The following is a description of a gene set: species: Mus musculus Mouse Gene Set: WP_OSTEOBLAST_SIGNALING Osteoblast signaling, and this is the list of marker genes: Pdgfra, Slc17a2, Pth, Tnfrsf11b, Bglap2, Fgf23, Col1a1, Tnfsf11, Pdgfrb, Pth1r